Given this list of marker genes PAMR1, CPB2, CLTRN, FXYD3, DPP4, GPR137B, KIF12, PKLR, ACE2, FBP1, SLC26A1, ETV5, PROC (protein C, inactivator of coagulation factors Va and VIIIa), HPGDS, DCT, CBS, HGFAC, TMED6, VLDLR, ATP7A, BCL6B, FBP2, GATM, PCSK9, NPTX2, CDHR2 (NCBI Gene Id 95968), FFAR2, PRLR, GLUL, PFKFB2, MLXIPL, SFXN2, CLIC5, ADAM32, MSH5, SLC12A7, CYP4V2, SLC40A1, TM4SF4, PFKP, COX6A2, RAB37, G6PC2, HOPX, UGT1A1, UGT2B4, SULT1C2, SLC2A2, AMBP, GOLT1A, IGF1R (NCBI Gene Id 51049), PFKL, GNG12, POU3F4, MAPK15, MUC4, SEMA4A, KDM2B, TRPM2, SLC37A4, PPP1R1A, COL27A1, PIGR (NCBI Gene Id 5284), KYAT3, SLC38A4, ENPEP, ANXA4, CDO1, SGK2, ELOVL2, GRTP1, WNK4, CDH8, TPI1, FOXA3 (forkhead box A3), VIL1, TTR, HCAR2, ANKS4B, NR1H4, PKHD1, HNF4A, SULT1D1P, ATP4A, PDK1, TRPM5, NDUFS2 (NCBI Gene Id 4720), PGK1, TMPRSS4, MTMR11, TAT, CCL28, GC, FH, DDC, ADH1A, GLP1R, CPN1, TACR3, MELTF, TMPRSS2, RNASE4, RNF186, SLCO1A2, ME3, FRK, PCSK1 (proprotein convertase subtilisin/kexin type 1), SERPINA10, here is a description of the gene set: Genes down-regulated in pancreatic islets upon knockout of HNF1A. Human Gene Set: SERVITJA_ISLET_HNF1A_TARGETS_DN from publication Servitja JM, Pignatelli M, Maestro MA, Cardalda C, Boj SF, Lozano J, Blanco E, Lafuente A, McCarthy MI, Sumoy L, Guigó R, Ferrer J (PMID 19289501) Heterozygous HNF1A mutations cause pancreatic-islet beta-cell dysfunction and monogenic diabetes (MODY3). Hnf1alpha is known to regulate numerous hepatic genes, yet knowledge of its function in pancreatic islets is more limited. We now show that Hnf1a deficiency in mice leads to highly tissue-specific changes in the expression of genes involved in key functions of both islets and liver. To gain insights into the mechanisms of tissue-specific Hnf1alpha regulation, we integrated expression studies of Hnf1a-deficient mice with identification of direct Hnf1alpha targets. We demonstrate that Hnf1alpha can bind in a tissue-selective manner to genes that are expressed only in liver or islets. We also show that Hnf1alpha is essential only for the transcription of a minor fraction of its direct-target genes. Even among genes that were expressed in both liver and islets, the subset of targets showing functional dependence on Hnf1alpha was highly tissue specific. This was partly explained by the compensatory occupancy by the paralog Hnf1beta at selected genes in Hnf1a-deficient liver. In keeping with these findings, the biological consequences of Hnf1a deficiency were markedly different in islets and liver. Notably, Hnf1a deficiency led to impaired large-T-antigen-induced growth and oncogenesis in beta cells yet enhanced proliferation in hepatocytes. Collectively, these findings show that Hnf1alpha governs broad, highly tissue-specific genetic programs in pancreatic islets and liver and reveal key consequences of Hnf1a deficiency relevant to the pathophysiology of monogenic diabetes. studied in species Mus musculus